Given this list of marker genes Fgfr1, Epb41l5, Vil1, Furin, Lamc2, Fat1, Ccar1, Dysf, Spn, Dock4, Adam7, Ntf3, Cd74, Slamf1, Akirin1, Dnm1l, Pdgfra, Angpt1, Hmox1, Ccl3, P2ry12, Bmp7, Ccl4, Iqgap1, Phpt1, Clec7a, Ccr1, Ccn4, Hif1a, Il16, Smo, Fgf16, Ccl21d, Itgax, Anxa3, Cd47, Itgav, S100a11-ps, Cfap69, Glipr2, Apc, Prkd2, Il1a, Zfp609, Adam17, Atm, Ccr4 (C-C motif chemokine receptor 4), Rhoc, Akt1, Pak1, Foxf1, Ccl21b, Fgf1, Sema4b, Rin2, Gas6, Il34, Itga3, Rab11a, Ccl5, Fzd4, Ptger4 (prostaglandin E receptor 4 (subtype EP4)), Cfap20, Gli1, Diaph1, Fam107a, Ptger3, Col18a1, Pfn1, Pik3cb, Igf1r, Rapgef3, Fam83h, Nr4a3, Zfp640, Ptafr, Angpt4, Bves, Sema3c, Plaa, Myo1c, Hdac4, Tmsb4x, Snai2, Arhgef39, Sema4c, Lef1, Calr, Dscam, Mien1, Sema3b, Elp3, Lgmn, Ccl19, Rock2, Hyal1, Cdh5, Coro1a, Tjp1, Ccl8, Vegfd, Cib1, Trf, Sema6a, Itga2b, Ednra, Rarres2, Rac1, Sphk1, Cttn, Shh (NCBI Gene Id 20423), Foxp1, Cxcl12, Cxcr2, F3, Atoh8, Myocd, Srpx2, Gfus, Sema6b, Fermt3, Bmp2, Xbp1, Tgfbr1, Syne2, Hspa5, Spinkl, Cldn3, Ccl19-ps1, Gria1, Ppm1f, Fgf10, Acta2, Zp3, Creb3, Amot, Myadm, Ephb2, Slit2, Ccn1, Dmtn, P2ry6, Tacr1, Rab25, Slc8a1, Ano6, Fpr-rs4, Grin1, Adam8, Abl1, Bcar1, Ptk2, Tmem201, Slc26a5, Ripor2, Fga, Egr1, Lgals3, Atp5f1a, Ube2i, Fam110c, Adora2b, Mmp7, Pdgfrb, Tac4, Sema4f, Mylk, Ret, Tnfaip6, Selenok, Lrrc15, Wnk1, Ezh2, Arf6, Carmil1, Carmil2, Ccr1l1, Fbxo31, Tbc1d24, Aqp1, Retn, Egf, Ccl2, Or4m1, Spag9, Ilk, Vsir, Duox1, Synpo2, Plau, Adora3, Sp1, Drd1, Pdgfa, Arpc2 (actin related protein 2/3 complex, subunit 2), Icam1, Akt3, Jak2, Tacr3, Thy1, Myoc, Dab2ip, Aif1, Cldn13 (claudin 13), Dapk3, Jam3, Hras, Fam89b, Cdh13, Pdgfb, Plp1, Ppbp, Gcnt2, Fn1, Duoxa2, Epha4, Myc, Cxcl10, Arhgap32, Serpine1, Gpld1, Smurf2, Flna, Atp8a1, Mmp14, Insm1, Mdm2 (transformed mouse 3T3 cell double minute 2), Pdpk1, Nus1, Crk, Hdac6, Fer, Foxc2, Rhod, Atp7a, Mapk8ip3, Prex1, Ptp4a1, Ccr2, Pla2g7, Mapre2, Tirap, Stk39, Sema4g, Pecam1, Tgfbr3, Rapgef4, Numb, Ccl26, Notch1, Pik3r1, Pde4d, Tradd, Hspb1, Ptn, Rras, Itgb1, Irs2, Cxcr4, Lyn, Dapk2, Sema7a, Mia3, Igf2, Zfp703, Cav1, Ccr6, Sh3rf2, Sash1, Reln, Epcam, Smad3, Akt2, Cmklr1, Fbxo5, Prkd1, Cbll1 (Casitas B-lineage lymphoma-like 1), Fpr2, Gab1, Map2k3, Plpp3, Defb37, Dock5, Uts2, Nfe2l2, Sucnr1, Ccl11, Gab2, Ackr3 (NCBI Gene Id 98703), Tnfsf18, Kitl, Angptl3, Prr5, Pik3cd, Tnfrsf14, Fut7, Cd99l2, Itga4 (NCBI Gene Id 16401), Zfp580, Vegfa, Wnt5a, Tfap2a, Kif20b (NCBI Gene Id 286943), Sdcbp, Hbegf, Map3k7, Clasp1, Acvr1, Sema5a, Plcg2, Grn, Trpv4, Wnt5b, Rtn4, Ptk2b, Irs1, Pcsk5, Plg, Rufy3, Casr, Stx4a, Cfl1, Tlr4, Elp5, Twist2, Vtn, Cpeb1, Cxcl14, Nipbl, Rps6kb1, Sema3e, Artn, Ror2, Pik3c2a, Ets1, Hgf, Irgc, Plcg1, Gper1, Insr, Cripto, Tert, Sema4d, Ccl6, Sparc, Cxcl13, Capn7, Sema3a, Cd274, Sema3f, Sod2, Trim32, Camk1d, Aoc3, Dock8, Bmp4, Cyp1b1, Vim, Gata3, Nox4, Fgfbp1, Wdr62, Elp6 (NCBI Gene Id 72341), Cldn4, Ntn1, Swap70, Tgfb1, Lamb1 (NCBI Gene Id 97822), Cd151, Kdr, Camk2d, Trem2, Ccl7, Rdx, Ifng, Dock1, Ccl9, Ccl19-ps3, Rnase10, Ccl21a, Fgr, Csf1, Pdgfc, Prox1, Lgals9, Met, Dab2, Ccdc25, Rras2, Sele, Bag4, Tac1, Vegfc, Gpi1, Bcas3, Sema6c, Dicer1, Zc3h12a, Rnase9, Mstn, Nos3, Tnfsf4 (NCBI Gene Id 226545), Stat3, Sema4a, Pax6, Vegfb, Edn2, Rhoj, Epha2, Mapk3, Med23, Itgb3, Tgfbr2, Il6st (NCBI Gene Id 71317), Fgf2 (NCBI Gene Id 14173), Plk2, Epha1, P2ry2, Podxl, Prkca, Mcu, Stk4, Cxcl16, C3ar1, Sell, Arhgap5, Gata2, Shtn1, Arhgef2, Pdpn, Myo5a, Igfbp5, Cx3cl1, Xcl1, Fpr-rs7, Jam2, Stat5b (NCBI Gene Id 20851), Bdkrb1, Sema3d, Sun2, Il1b, Cass4, Ccl19-ps6, Hdac7, Insl3, Daam2, Itga2 (integrin alpha 2), Ccl19-ps5, Ptgs2, Mmp1a, Tacr2, Acp5, Onecut1 (NCBI Gene Id 52327), Pld1, Il18, C5ar1 (complement component 5a receptor 1), Tmem102, Anxa1, Fut4, Smim22, Mdk, C1qbp, App, Ccl12, Fbln1, Map2k1, Ripor1, Wnt7a (NCBI Gene Id 22421), Fpr-rs3, Trp53, Bsg, Fubp1, Atp5f1b, Rapgef2, BC037156, Map4k4, Apela, Foxo4, Crkl, Ctsh, Pycard, Csf2, Postn, Sox9, Pgf, Spi1, Smoc2, Egfr, Ntrk3, Tek, Pdcd10, Mcam, Map2k2, Alox12, Oxsr1, Col1a1, Rhoa, F2r, Ptprc, Actg1, Myo1f, Tsc2, Pik3cg, Tlr2, Emc10, Epb41l4b, Has2, Cpne3, Ccbe1, Cavin1, Tiam1, Src, Acvr1b, Fut1, Pawr, Edn1, Ccr7 (NCBI Gene Id 12775), Casp8, Tnfsf14, Jcad, Edn3, Cdc42, Prl2c2 (prolactin family 2, subfamily c, member 2), Prkce, Flt4, Tac2 (tachykinin 2), Lpar1, Actn4, Adam9, Plet1, Ptprj, Il12a, Ascl2, Lgr6, Aldoa, Cd40, Tnfrsf18, Hmgb1, Adgra2, Ptprz1, Rack1, Iqcf1, Plvap, Bcl2, Mmp3, Bmpr2, Grb7, Pdcd6, Ago2, Cldn7, Ccl24, Spry2, Gpsm3, Rreb1, Defb25, Ddr2, Clasp2, Lrp1, Il23a, Syde1, Itgb1bp1, Actr3, Pak3, Thbs1, Ddrgk1, F2rl1, Itga6, Nrp1 (neuropilin 1), Lyve1 (lymphatic vessel endothelial hyaluronan receptor 1), Fgf7, Csf1r, Map3k3, Twist1, Mgat5, Kit, Itga5, Trem1, Gpnmb, Rhob, Pdgfd, Vps35, Mospd2, Il1r1, Il4 (interleukin 4), Rac2, Cldn1, Ccl19-ps4, P4hb, Abl2, Hdac9, Mmp9, Perp, Gnai2, Ccl22, Pld2, Ppp3ca, Sirt1, Madcam1, Nckap1l, Ssh2, Mapk1, Mmp2, Cxcr3, Onecut2, Scrib, Lcn2, Maz, Stat5a, Nsmf, Thbs4, Akap12, Enpp2, Fpr-rs6 (NCBI Gene Id 321020), Igf1, Agt, Amotl1, Nedd9, S1pr1, Sema6d, Ccl1, Iqsec1, Sec1, Adra2a, Ccl21e, Pgr, Stx3, Bcl6, Megf8, F7, Fermt1, Cx3cr1, Sema3g, Prdm14, Adam10, Selp, Fermt2, Ager, Abcc1, Fgf18, Wasl, Sema5b, Ccl20, Jun, Lbp, Tgfb2, Cxcl17, Flt1, Ssh1, Cep43, S100a11, Snai1, Ccl21f, P2rx4, Cemip, Adamts1, Defb1, Trip6, Duox2, Mapk8, Scg2, Fgf9, Tpbg, Fadd, Erbb4, Mtor, Ccl25, Nox1, Dock7, S100a14, here is a description of the gene set: Mouse Gene Set: GOBP_POSITIVE_REGULATION_OF_LOCOMOTION studied in species Mus musculus Any process that activates or increases the frequency, rate or extent of locomotion of a cell or organism.